Given this list of marker genes Shc2, Grb2, Ralgds, Shc1, Mapk14, Mapk11, Hras, Shc3, here is a description of the gene set: This event has been computationally inferred from an event that has been demonstrated in another species.<p>The inference is based on the homology mapping from PANTHER. Briefly, reactions for which all involved PhysicalEntities (in input, output and catalyst) have a mapped orthologue/paralogue (for complexes at least 75% of components must have a mapping) are inferred to the other species. electronically inferred by orthology from the curated human pathway part of: Signalling to ERKs studied in species Mus musculus Reactome Pathway: Signalling to RAS